Given this list of marker genes PLK1, RAN, TUBB1, SDCCAG8, TUBA1A, DYNLL1, ABRAXAS1, DSCC1, H3C8, H3C6, ANAPC10, TPR, CEP192, PSMB4, RFC1, NUP43, SFI1 (NCBI Gene Id 9814), NEDD1, HUS1 (HUS1 checkpoint clamp component), TINF2, UBE2S, MAPK1, GORASP1, CEP76, TUBB3, RB1, CEP135, KAT5, NIPBL, BRCC3 (BRCA1/BRCA2-containing complex subunit 3), RAD9B, CDC23, POLR2A, CDC14A, H2BC6, TUBG2, H3-3B, AAAS, PSMA7, H2BC12L, CEP57, SGO1, PRIM1, UBC, SMC3, ORC1, CENPN, NUMA1, DYNC1LI2, H2AC7, KIF18A, H2AX, ACTR1A, CDKN1A, CEP70, RPA2, RBL1, TUBB8, H3C15, GAR1, FEN1 (NCBI Gene Id 5882), DBF4, TUBA4A, FIGNL1, PSMB2, NME7, CENPK, MYC, RAD17, H2BC9, BUB3, RPA4, ARPP19, LEMD2, CDK1, LBR, CDKN1B, WRN, NUP107, DCTN2, GINS4, SKP2, CLIP1, LPIN2, ORC4, H2BC26, POT1, RAD51, RNF168, TUBB2A, H2AZ2, MZT2A (mitotic spindle organizing protein 2A), POLR2H, POLE, CCND3 (cyclin D3), PSMD3, CENPU, PSMC6, YWHAB, RCC2, CDK5RAP2, CTDNEP1, CENPT, H2AC20, RNF8, CEP72, ORC5, H2BC7, SIRT2, PRKAR2B, PSMA3, TUBA1C, HAUS8, STN1, E2F2, DCTN3 (NCBI Gene Id 11258), CENPH, TOP2A, CDK11B, CDC25B, AKT2, H3C13, RAB1B, BARD1, PCNA, TUBA3E (NCBI Gene Id 150521), PPP2R5B, EXO1, LMNB1, HAUS6, CENPE, LIN9, MCM4, CDC25A, H4C8, CHTF18, H3C1, NDC80, UBB, LEMD3, CDC6, NUP62, ANKRD28, LIN52, BANF1, PAFAH1B1, NUP155 (nucleoporin 155), NEK7, HJURP, LIG1, ANAPC15, TOPBP1, ITGB3BP, PDS5A, CEP63, CDK6, PHF8, SYCE1, POM121C, CHMP4C, MAPRE1 (NCBI Gene Id 22919), STAG3, CHMP4A, PHF20, AHCTF1, TUBB8B, SPC25, EML4, PSMC3, POLD1, NHP2, KMT5A (NCBI Gene Id 387893), CDC20, CEP164, NINL, GTSE1, DCTN1 (NCBI Gene Id 82109), PDS5B, NUP58, PPP2R2A, CENPF, IST1, PSMA4, GSK3B, TUBB2B, GORASP2, CCNH, SMARCA5, ORC6, ANAPC7, CENPS, POM121, RBX1, SUN1, PSMC3IP, DAXX, CUL1, H4C12, MAPK3, NUP93, PTK6, CDC7, PPP1R12B, H2BC11, H2BC5, TUBGCP5, LMNA, SKA1, NUP85, CKAP5, PPP2R5A (protein phosphatase 2 regulatory subunit B'alpha), SKP1, RAD21 (RAD21 cohesin complex component), NUP50, NPM1, PPP2R5E, SYCP3, HDAC1, PPP1CC, CEP250, WRAP53, H2AC8 (H2A clustered histone 8), MCPH1, KNTC1, GINS2, HERC2, PKMYT1, CDK11A, CENPX, MND1, PSMD6, H2AC6, RPS27A, H3C11, CCND1, ODF2, AKT1, COP1, NCAPG2, POLR2D, SYNE2, BABAM2, CCNA2, H4C3, HSPA2, BUB1 (BUB1 mitotic checkpoint serine/threonine kinase), STAG2, PRKACA, FBXW11, PRIM2, SYCE2, CENPQ (centromere protein Q), PSMD13, ANAPC2, PSMA1, KIF2A, TUBGCP3, UBE2N, BLM (NCBI Gene Id 641, BLM RecQ like helicase), FKBPL, CCP110, TUBB4A, ORC2, CDC26, CDK2, CHMP2B, H4C4, NUP133, H4C14 (NCBI Gene Id 8370), OPTN, MAX, H2BC17, ESPL1, RBBP7, EP300, SPC24, PSMC4, STAG1, BRCA2, SYNE1, E2F4, CEP152, E2F6, CDK4, H3C7, TP53BP1, MYBL2, ENSA, NEK2, SET, RSF1, H3C10, CC2D1B (NCBI Gene Id 84499), SKA2, NEK6, TAOK1, NCAPD2, PSMD8, PSMB7, UBE2V2, H2AJ, RAB1A, HDAC8, LPIN1, CENPJ, FZR1, CDCA8, WEE1, PSMA6, HAUS2, LYN, CETN2, POLR2K, ZNF385A, NUP37, ESCO2, PPME1, NDE1, PSMD2, YWHAG, TUBB4B, CDCA5, AKAP9, HAUS3, SSNA1, RBL2, YWHAH, TERF2, RAE1, PPP6R3, H2AC4, CDKN2D, RFC5, MZT2B, OFD1 (NCBI Gene Id 8481), NCAPH, H4C6, PRDM9 (NCBI Gene Id 56979), NUP35, HAUS4, NSD2, CDC27, PCNT, POLD4, H2BC1, CDKN1C, TMPO, HAUS7, DYNLL2, YWHAQ, POLR2J, RANBP2, NUP205, FIRRM, UBE2I, RFC3, KIF23, TUBA4B (NCBI Gene Id 80086), E2F3, ACD, TUBA3D, POLA2, POLR2E, MSH4, HSP90AB1, LIN37, H2AC14, TUBGCP6, PPP2CA, MAD1L1, PPP6C, RBBP8, CCNE1, NUP188, PCM1, PPP2R5D (NCBI Gene Id 5528), FBXL18, ANAPC4, SYCP1, LCMT1, YWHAZ, H2BC15, RANGAP1, PSMC2, TUBGCP4, LIN54, MCM5, HAUS5, SPDL1, PSMA2, NCAPG, RPA3, H3C14, ATR, ATM, POLE2 (NCBI Gene Id 5427), B9D2, TK1, PIF1, NUDC, UBE2C, MSH5, TFDP1, CHTF8, H3C4, POLE3, CEP290, XPO1, DYRK1A, POLR2L, POLR2G, TOP3A, DHFR, DYNC1LI1, TERF2IP, H3C12, SMC1A, PPP2R1A, NDC1, AJUBA, NUP153, CEP131, LPIN3, OIP5 (Opa interacting protein 5), TUBG1, GINS3, POLD3, PSMD12, ORC3, H2BC21, PTTG1, H2AC19, AURKA, ANAPC11, BTRC, CDC25C, ATRX, SPO11, NCAPH2, PRKCA, CDKN2A, PIAS4, RPA1 (NCBI Gene Id 6117), TUBAL3, RAD1, FOXM1, CENPA, EMD, RAD9A, CSNK2A1, NDEL1, NUF2, SEM1, REC8 (NCBI Gene Id 9985), TICRR, NUP42, KPNB1, H2BC12, SYCP2, CDK7, CDT1, KNL1, DYNC1I1, CLASP1, CDC45, BRIP1, H4C13, TPX2, TEX15, PPP2CB, H3C2, PPP2R2D, CENPI, BORA, ZW10 (NCBI Gene Id 9183), PSMD11, H4C5, SGO2, CENPM, PPP2R5C, DYNC1I2, CHMP3, RMI2, H2BC3, RUVBL1, CCND2, MCM3, RBBP4, PLK4, H2BC8, CHEK1, MDC1, ANKLE2, PPP1CB, MIS12, MAU2 (MAU2 sister chromatid cohesion factor), ATRIP, FBXL7, ESCO1, GINS1, PSMD1, MCM6, SFN, CEP41, CHMP7, MLH1, HSP90AA1, PRKCB, ZWILCH, RAB8A, PSMA5, SYCE3, MCM7, PCBP4, ERCC6L, VPS4A, E2F1, DNA2, H3-4, SEH1L, POLR2B, CSNK1E, UBE2D1, AKT3, RPS27, CEP78, POLD2, CDC16, ABL1, PPP2R1B, CSNK2B, MLH3, CENPW, PSMB3, TUBA1B, MDM2, RFC2, MASTL, ALMS1, PMF1, PHLDA1, POLE4, TP53, AURKB, E2F5, CNTRL, TUBB, H4C2, CEP43, MAD2L1, MCM10, ADRM1 (NCBI Gene Id 11047), PSMB1 (NCBI Gene Id 5689), PSMB5, ANAPC5, PPP1R12A, CHMP6 (NCBI Gene Id 79643), TERF1, MCM2, H4C11, BIRC5, POLR2F, TERT, MZT1, TUBGCP2, NUP88, VRK1, H2BC10, CSNK1D, MNAT1, NBN, RAD50, CCNB2, MRE11, DIDO1 (death inducer-obliterator 1), INCENP, CHMP4B, POLR2I, TUBB6, CDKN2B, BABAM1, RHNO1, RTEL1, NUP210, CENPL, MDM4, TUBA8, CABLES1, DYNC1H1, PSMC1, BUB1B, TYMS (NCBI Gene Id 7298), YWHAE, KIF20A, BLZF1, CCNA1, SMC2, H4C15, CENPC, PSMC5, UBE2E1, CNEP1R1 (NCBI Gene Id 255919), RAD51C, KIF2B, CSNK2A2, MCM8, CCNB1, NUP54, ANAPC1, H2AC18, NUP160, RFC4, MIS18A, RCC1 (regulator of chromosome condensation 1), CHEK2, FKBP6, SMC1B (structural maintenance of chromosomes 1B), H4C16, CHMP2A, CLASP2, HAUS1, PSMD14, PSMB6, CLSPN, NSL1, DMC1, RUVBL2, RRM2, TEN1, CENPP, NCAPD3, DSN1, PPP2R3B, CTC1, H2BC14, CKS1B, CENPO, WAPL, TFDP2, TNPO1, TEX12, POLR2C, MIS18BP1, SHQ1, CDKN2C, RAB2A, USO1, H2AB1, RMI1, HMMR, GOLGA2, NOP10, SEC13, NUP214, OBI1, UIMC1, DKC1, ZWINT, FBXO5, ANAPC16, PSMD7, H2BC4, VRK2, TUBA3C, H4C9, SMC4, H4C1, SPAST, H2BC13, NUP98, SUN2, GMNN, SRC, NEK9, H3-3A, JAK2, SUMO1, BRCA1, POLA1, H3C3, UBA52 (ubiquitin A-52 residue ribosomal protein fusion product 1), KIF2C, CCNE2, here is a description of the gene set: Human Gene Set: REACTOME_CELL_CYCLE species: Homo sapiens Cell Cycle